Given this list of marker genes Drd4, Krt1, Gabarapl1, Krtap19-2, Krtap9-3, Dnah1, Tbca, Dync1li2, Pum1, Dnajb6 (NCBI Gene Id 23950), Saxo2, Arhgap33os, Fign, Cct2, Dcp1a, Krtap16-1, Smg5, Lmod2, Grsf1, Larp1, Krt14, Pbxip1, Grin2b, Mtcl2, Fbln5, Dnah12, Col1a1, Dcdc2c, Myom3, Snph, Chmp1b2, Synj1 (synaptojanin 1), Chmp4b, Dync1li1, Tstd1, Mical1, Slmap, Atxn2, Edc4, Hax1, Diaph1, Myo18b (NCBI Gene Id 74376), Katnb1, Coro1b, Cfap95, Misp, Larp4b, Diaph2, Luzp1, Spout1, Rptor, Cul3, Cfap210, Cfap144, Nudc, Spc25, Keg1, Igbp1, Vps11, Map2k1, Spast, Krt35, Eif4ebp2, Krt19, Fmn1, Krt7, Mex3b, Pierce2, Dnah17, Mefv (Mediterranean fever), Cfap77, Lman1, Fastk, Shroom3, Ska1, Septin9, Rpusd3, Amelx, Samd4b, Krtap6-5, Dync2li1, Cep57, Col5a3, Vmac, Dcdc2b, Ppp1r12b, Krtap5-5, Ythdc2, Endov, Arhgef25, Ryr1, Tiam1, Baiap2, Septin7, Rpgrip1l, Ogfod1, Ss18l1, Obscn, Lzts2, Ankrd34c, Map1b, Krtap19-3, Nme2, Gm5478, Kat8, Cenpq, Krtap5-2, Clmp, Inpp5d, Smarcb1, Ddx3y, Krtap3-3, Kif19a, Grip1, Spaca9, Pdlim7, Hook3 (NCBI Gene Id 76095), Efhc1, G3bp1 (NCBI Gene Id 97760), Golga2, Tubgcp6, Myh13, Pygm, Plk2, Trim54, Shank2, Limd1, Jph2, Smarcc1, Nrap, Aspm, Mapre1, Mid1ip1, Cep170, Dbnl, Col4a2, Kcnab2, Plk1, Calm3, Abra, Cenpu, Csrp1, Acta2, Lmna, Akap4, Saxo4, Cdk2ap2, Cnot8, Haus6, Odf4, Map1lc3b, Tuba4a, Tubgcp4, Gng12, Synpo2, Kif9, Usp3, Sco1, Pgm1 (phosphoglucomutase 1), Krtap19-9b, Clasp2, Krtap4-6, Des, Kif21a, Tubb1, Rps4x, Ttll3, Cenpf, Fam161a, Camsap2, Slc8a2, Tpm3-rs7, Eml2, Ccsap, Hnrnpa3, Matcap1, Keap1, Camsap3, Tmem214, Eid1, Calm2, Myo1f, Krt20 (NCBI Gene Id 66809), Cryab, Cct7, Frg1, Myl9, Tbcb, Chmp1a, Serpinb1a, Abcc9, Phf2 (PHD finger protein 2), Cdk5rap2, Myod1 (NCBI Gene Id 17927), Slc2a1, Ddx3x, Knl1, Krtap6-2, Kpna2, Lsm4, Rpl15, Bard1, Fhl3, Uhmk1, Krtap8-1, Adamtsl5, Marcks, Ankrd1, Krtap14, Tekt4, Cfdp1, Lmntd2, Asz1, Psen2, Cldn11, Cdt1, Opa1, Ctsg, Tnni2, Map10, Ribc2, Krt85, Klc3, Nsun2, Casc3, Fastkd1, Ino80, Krt84, Kif14, Myo9b, Tubgcp3, Poldip3, Kif16b, Radil, Tdrkh, Rab11a, Dpysl2, Piwil1, Nes, Lrpprc, Ccnb1, Cenph, Pcbp1, Kntc1, Cdk1 (NCBI Gene Id 12534), Cfap53, Lrrc39, Col11a1, Knstrn, Klc1, Arpc3, Ago1, Smtnl1, Haus1, Ctps2, Twf1, Togaram2, Cnot2, Krt222, Kcnn3, Cfap45, Tpgs2, Tubb5, Clip1, Bex6, Nefh (neurofilament, heavy polypeptide), Tcp11l1, Elavl1, Krt76, Casq2, Thsd4, Pls3, Tubg2, Timp4, Lin28a, Hsph1, Mfap5, Abi2, Cfap68, Apc, Eln, Gtsf1, Polb, Cfap161, Haus4, Dusp22, Saa2, Tnrc6c, Rassf3, Krt87, Shfl, Map6, Trp53bp1, Noct, Daxx, Cst3, Rps6, Pdlim2, Cyld, Tubb3, Cct3, Cenpe, Krt73, Fbn2, Lsm2, Tuba1c, Kif1a, Odf1, Mybpc3, Ezr, Lcp1, Firrm, Mta1, Mov10, Tnni3, Cald1, Krt40, Ttl, Nuf2, Slc1a4, Map6d1, Cfap96, Bag3, Mfap4, Katna1, Mt3, Ldb3, Fgf13, Pdlim3, Mael, Igfn1, Pbrm1, Eml6, Src, Gsk3b, Spmip10, Kif2b, Anapc16, Dctn4, Stmn1, Mfap2, Tuba1b, Cd2ap, Pyroxd1, Hnrnpu, Rac2, Kif17, Tmod4, Fhod3, Phf10, Ift70a1, Krt26, Synpo, Bin1, Nup160, Fbxo22, Mypn, Kif2c, Tmsb15b2, Rhoq, Stim1, Ndrg1, Eml1, Mapre3, Map1a, Cdk9, Lima1, Stau2, Whamm, Ift70b, Hnrnpa2b1, Ryr2, Tcp1, Arid2, Invs, Pinx1, Tmsb15l, Efcab6, Yes1 (NCBI Gene Id 22612), Krt5, Ttll9, Reep2, Klhl40, Mapt, Cobl, Zfp804a, Myh10, Npnt, Krt86, Hid1 (HID1 domain containing), Myot, Lsm3, Lsm1, Fkbp1a, Pde4dip, Fastkd5, Dync2h1, Gtf2b, Casp1 (NCBI Gene Id 12362), Krt74, Kif18a, Pnrc1, Kif28 (kinesin family member 28, NCBI Gene Id 383592), Krt83, Dynlrb2, Nrp1, Arhgap18, Klhl21, Nckap5, Phf6, Krt33a, Kif3b, Ghr, Cltc, Ldlrap1, Nckap5l, Tube1, Cfap141, Myh2, Adamts10, Gas2l2, Lmod1, Alppl2, Specc1, Qki, Isg20, Arhgef2, Rps6-ps4, Garre1, Myh11, Krt15, Trip10, Gramd2b, Kifc5b, Cfap107 (NCBI Gene Id 69364), Ccdc66, Fez1, Dcn, Ercc6l, Nup107, Tnk2, Fhdc1 (FH2 domain containing 1), Kcnj8, Shroom4, Synm, Rpusd4, Cenpm, Cct4, Flacc1, Grk3, Prpf4b, Dnai2, Tubg1, Fermt2, Ssb, Tmod3, Hnrnpl, Myh3, Tsc1, Bub1, Kif4, Tuba1a, Col27a1, Cimip2b, Zwint, Nefl, Krtap7-1, Sncaip, Nicn1, Tpr, Scn1a, Fmr1 (NCBI Gene Id 207836), Incenp, Nefm, Mis12 (NCBI Gene Id 67139), Xirp2, Nos1ap, Ybx1, Krtap3-2, Chmp7, Cfap90, Tcap, Snrpg, Krtap15-1, Mcrip2, Dmtn, Krt10, Tlk2, Dag1, Col4a1, Cdk5, Mfsd2a, Fxr1 (FMR1 autosomal homolog 1), Rpl28, Ror2, Cenpt, Zfand1, Bfsp2, Eif4a1, Mid1, Sdc4, Fam184a, Bloc1s6 (biogenesis of lysosomal organelles complex-1, subunit 6, pallidin), Tnnt1, Actg1, Reep4, Larp4, Vcp (valosin containing protein), Krt2, Gas7, Dcdc2a, Nup133, Col4a3, Smarca4, Aicda, Espn, Arl6, Col3a1, Rnf135 (NCBI Gene Id 71956), Spag8, Dctn5, Tjp1, Krt9, Map3k1, Pabpc4l, Myl4, Slc8a1, Amot, Psen1, Spmip9, Myom1, Cfap206, Syne1, Slain1, Abraxas2, Myh6, Sqstm1, Parvb, Upp2, Btbd1, Clip2, Prkaa2, Plk3, Myh4 (myosin, heavy polypeptide 4, skeletal muscle), Trim21, Bcl10, Synj2, Krt80, Hjurp, Dnah5, Rock1, Krt31, Myo18a, Kcne1, Ttll11, Gabpb1, Gck, Fxr2 (NCBI Gene Id 23879), Krtap19-4, Cspp1, Rock2, Ttll1, Htr2a, Mtus2 (NCBI Gene Id 77521), Trim5, Dnajb4, Nav1, Col11a2 (NCBI Gene Id 12815), Lrwd1, Exd1, Sptbn1, Mark2, Edc3, Shroom2, Fkbp4, Rangap1, Eif4enif1 (NCBI Gene Id 77952), Dis3l2, Dnai1, Poli, Snca, Hook2, Actn1, Tuft1, Pabpc2 (NCBI Gene Id 18459), Krtap26-1, Syne2, Map2k2 (NCBI Gene Id 26396), Whrn, Simc1, Tdrd7, Dhx36 (DEAH-box helicase 36), Tut4, Col1a2, Hrc, Tex14, Kifc2, Dynlt1b, Ctnnb1, Myl2, Tdrd1, Gsn, Krt34, Enkd1, Tpm2, Fsd1, Numa1, Dync1i1 (NCBI Gene Id 209813), Hoxd10, Patl1, Csrp2, Chmp2a, Was, Tnnt3, Pkp1, Scn8a, Krt75, Slc39a2, Jph1, Samd4, Kif5a (NCBI Gene Id 52905), Stau1, Rmdn3, Rab3d, Dnai7, Kmt5b, Cct5, Rtl1, Col6a1, Eif4e2, Ddx28, Cav3, Nin, Klhl22, Rplp0, Ythdf3, Fbxo32, Tnnc2, Dnm1, Tmem232, Kif3c, Tia1, Scn3b, H3f3a, Nbr1, Map3k11, Fyn, Cdc42, Trim71, Slc8a3, Ninl, Myoz2, Pde4d, Spry2, Csde1, Sybu, Ccnb1-ps, Champ1, Actg2, Wdr47, Tppp3, Pls1, Cct8, Jakmip1, Lmnb1 (lamin B1), Myl7, Glrx3, Cab39, Mybphl, Rc3h1, Efhc2, Ttk, Khsrp, Fkrp, Pdlim1, Tpt1, Krtap3-1, Fbf1, Psma4, Vps18, Dcp1b, Ndc80, Ago4, Zfp276, Krt27, Ido1, G3bp2, Csnk1d, Krt6b, Rusc1, Krt25, Tubb2b, Slc25a54, Kif13a, Actn4, Cimip2c, Adora2a, Ankrd2, Gas2l3, Synpo2l (synaptopodin 2-like), Acte1, Ppp3ca, Xrn1, Rnf4, Zc3h12d, Serp1, Col4a4, Kif5c, Dhx9, Myo3a, Pecam1, Eml4, Krtap21-1, Gdpd2, Igf2bp1, Myh8, Dnah2, Krt17, Adra1a, Spag17, Nanos2, Tuba8, Spc24, D1Pas1, Ttll7, Sgo1, Krtap29-1, Hcls1, Trim30c, Smarce1, Ttn, Nxf1, Sntb2, Krt79, Kif21b, Cyp2a4, Ang, Henmt1, Tnni1, Casp14, Krt36, Afap1, Dnaja3, Cma1, Sugt1, Trim32, Ift70a2, Cimap1d, Ackr2, Lmnb2, Myo5a, Fbxo28, Kif20b, Pabpc4, Appbp2, Myl1, Ddx1 (NCBI Gene Id 104721), Sec13, Plec, Fam83h, Cstpp1, Cenpi (NCBI Gene Id 245603), Togaram1, Plk5, Cnot9, Spmip11, Krt77, Tekt3, Dlg1, Nsl1, Kcna5, Kpnb1, Snrpb2, Macf1, Krt32, Nfkbiz, Ankrd23, Scn5a, Eif4e, Dvl1, Mybph, Myh7b, Dst, Hspa8, Sphkap, Nek2, Efemp2, Dcxr, Neb, Krt13, Xpo1, Actbl2, Dctn1, Sarm1, Nup85, Fbxl22, Cenpj, Sync, Rpl17, Fbp2, Rbpms, Rassf2, Piwil4, Slc4a1, Csrp3, Krt12, Bpi, Nme1, Krtap5-3, Sptan1, Adprhl1, Nde1, Tpx2, Capn3, Sco2, Socs1, Kif6, Odf2, Krt81, Zar1, Ttll10, Col4a6, Mdm1, Dnal4, Svil, Lmntd1, Cyp2a5, Parp4, Cfl2, Trappc12, Col4a5, Reep1, Myh14, Rac1, Odam, Helz, Rec8, Kctd6 (potassium channel tetramerisation domain containing 6), Khnyn, Ppp1r12a, Tubd1, Kcnn1, Zfp207, Clock, Sin3a, Dek, Rmdn2, Acta1, Nav3, Krtap19-5, Rbm4, Mybpc1, Cenpc1, Pof1b, Sgo2a, Kbtbd13, Pnrc2, Rbm20, Iqgap2, Rsph1, Ythdf1, Pdlim4, Cttn, Ltbp1, Ttll5, Aldoa, Dmd, Apc2, Hspb1, Fastkd3, Prkd1, Specc1l, Ahctf1, Twf2, Ddx25, Zc3h12c (NCBI Gene Id 330940), Ncl, Krt33b, Kif13b, Trim30d, Ska3 (spindle and kinetochore associated complex subunit 3), Myo9a, Dnm1l (NCBI Gene Id 74006), Psmc3, Lmod3, Jup, Mbnl1, Pgm5, Arf1, Kif7, Katnal2, Mmp2, Tppp, Cenpx, Coro1a, Chmp4c, Dync1h1, Hook1, Gjb6, Hnrnpk, Dynlt2a1, Btbd2, Actr3, Nup37, S100a1, Vim, Cfap126 (cilia and flagella associated protein 126), Upf2, Kif5b, Gigyf2, Krt42, Igf2bp3, Shtn1, Krtap19-1 (NCBI Gene Id 170657), Gabarap, Tekt2, Dnah8, Tpgs1, Fam110a, Col2a1, Aurkc, Tubgcp5, Sri, Atat1, Wipf1, Klc2, Krt6a, Ckap2, Ryr3, Kifap3, Tardbp, Rpl6l, Rpl4, Pmf1, Ythdf2, Dynlt3, Krt71, Map2, Dctn3, Parva, 3425401B19Rik, Trim12a, Shb, Myh15, Dcp2, Cct6a, Cnot7, Gm5414, Krtap5-4, Haus8, Kif1b, Krt4, Upf1, Ank1, Ddx4, Ttll8, Mtm1, Actb, Nexn, Eppk1, Zar1l, Calm1, Smg1, Nanos3, Rgs14, Mid2, Srprb, Palld, Bcas3, Kptn, Cenpp, Ribc1, Cavin4, Nudcd2, Bicd1, Trim30b, Pabpc1, Kif15, Smc1a, Ttll13, Vcl, Ttll4, Zw10, Celf1, Flnc, Psrc1, Atp2a1 (NCBI Gene Id 11937), Eif2s1, Rac3, Igf2bp2, Tdrd9, Itgb1bp2, Eif6, Myo1a, Clasp1, Clip3, Fkbp1b, Sumo1, Pabpc1l, Cep57l1, Chmp6, Ocm, Nbdy, Fmn2, Efhb, Krtap16-3, Actn2, Rpl6, Tbrg4, Smarcc2, Pqbp1, Dpp9, Mfap1a, Cdc20, Cacna1s, Krt24, Myl12a, Rmdn1, Mybpc2, Grb7, Wdr44, Itgb3bp, Dlc1, Tubal3, Sh2b2, Krt8, Pak1, Ina (internexin neuronal intermediate filament protein, alpha), Tektl1, Htt, Map1s, Haus3, Carhsp1, Flna, Jam3, Map1lc3a, Krtap5-1, Ubap2l, Katnal1, Casq1, Pawr, Dusp21, Csnk1a1, Kif19b, Kcnn2, Hipk2, Krt28, Pabpc6, Cpeb1, Tubb4b, Tpm3, Cep170b, Mex3a (mex3 RNA binding family member A), Dnm2, Ddx19a, Mfap1b, Aif1, Eif4g1, Ppp6r2, Mad2l1, Cmya5, Wdr90 (WD repeat domain 90), Ky (kyphoscoliosis peptidase), Kif12, Polr2g, Fhl2, Tubb6, Dynll2, Arfgef2, Chmp1b, Cfap52, Sirt2, Tuba3a, Nup43, Smpx, Homer1, Fbln1, Capzb, Ank3, Dcx, Krt78, Arc, Sympk, Nckap1, Kansl1, Ctsh, Kif27, Gpatch11, Lsm14b, Kif26b, Caprin1, Fam110c, Cirbp, Crhbp, Tnnc1, Eml5, Shroom1, Dbn1, Mx2, Dysf, Spef1, Dynll1, Rassf5, Txndc2, Sctr, Akna, Dsn1, Krt23, Cacna1d, Pcp4, Septin2, Kif26a, Wtip, Helz2, Ckap5, Kif20a, Cep295, Rtn2, Dapk3, Carmil1, Pum2, Atp2b4, Lrrc49, Tnrc6a, Krtap12-1 (keratin associated protein 12-1), Mov10l1, Haus5, Trim30a, Dpysl3, Eml3 (echinoderm microtubule associated protein like 3), Dcps (NCBI Gene Id 69305), Kif18b, Piwil2, Fbn1, Trim25, Gsk3a, Brd7 (bromodomain containing 7), Selenos, Arl3, Meikin, Map7d2, Hck, Dnal1, Saxo1, Kat2b, Fam161b, Cfap276, Spag6l, Bub3, Stk11, Tnrc6b, Ptges3, Col5a1, Smarcd2, Ablim2, Sgo2b, Iffo1 (intermediate filament family orphan 1), Mtmr12, Trpv4 (NCBI Gene Id 80591), Apoe, Psmc2, Nusap1, Prrc2c, Evpl, Kif23, Ggps1, Tubb2a, Gfap, Hsf1, Ago3, Kif2a, Avil, Haus7, Pafah1b1, Zc3h12a, Cbx5, Dnah3, Col10a1, Bex4, Kif1c, Rassf1, Capn6, Crebbp, Tdrd6, Ank2, Ssna1, Clip4, Kifc3, Dbi, Tppp2, Serpinb1c, Aurkb, Rcc2, Trim12c, Tpm4, Lsm6, Mapre2, Ccdc181, Smn1, Bfsp1, Saa1, Myl12b, Fbxw11, Spag4, Tfpt, Prickle4 (NCBI Gene Id 381104), Bysl, Ppp3cb (protein phosphatase 3, catalytic subunit, beta isoform), Trpc1, Cimap1a, Myh9, Cnot1, Myom2, Mad1l1, Ilk, Ltbp4, Fhl5, Ptpn20, Pan2, Hdac6, Flnb, Meaf6, Kif3a (NCBI Gene Id 192824), Septin6, Krt82, Myl3, Tnnt2, Anxa5, Dyrk3, Diaph3, Krt18, Ddx6, Gtse1, Nebl, Pycard, Map7, Smarcd1, Spmip5, Top1, Iffo2, Zfp36l1, Cfap20, Vps16, Gas2l1, Kif24, Dync1i2, Pierce1 (NCBI Gene Id 69327), Actl6b, Chmp5, Map9, Krt16, Col28a1, Mef2c, C9orf72, Mns1, Polr2m, Ago2, Tekt1, Stub1, Pacrg, Iqgap1, Dnm3, Krt72, Bbln, Krt39, Apobec3, Nufip2, Dynlrb1, Pcnt, Actc1, Emd, Arhgap4, Habp4, Myoz1, Haus2, Ncapd3, Myo1c (NCBI Gene Id 97728), Psma6, Taf5l (TATA-box binding protein associated factor 5 like), Myh7, Spmip8, Disc1, Dctn2, Gja1, Hdac4, Dsp, Gper1, Cenpo, Cnot3, Mtcl1 (microtubule crosslinking factor 1), Bmal1, Styxl2, Tdrd5, Zc3h12b, Rem1, Tubb4a, Pabpc5, Chmp3, Birc5, Trim63, Slain2, Ttll6, Bub1b, Myo6, Dazap2, Eif3b, Myzap, Sarnp, Ccdc57, Kif22, Cep162, Bod1, Lrrc10, Spag5, Cdk5r1, Ppl, Mcrip1, Fastkd2, Arpc2, Tubgcp2, Bcl2l11, Tchp, Rbfox1, Cacna1c, Cenpw, Lsm14a, Lum, Znfx1 (NCBI Gene Id 98999), Sorbs2, Reep3, Aif1l, Zwilch, Actn3, Cnp, Spdl1, Narf, Cenpk, Cenpn, Zfp36, Mical2, Kif11, Kat5, Nos1, Cenpl, Nup98, Cenpv, Rbpms2, Ppp2r5a, Tial1, Prph, Hnrnpab, Myh1, Mir23a, Actl6a, Myo1b, Bag2 (BCL2-associated athanogene 2), Rc3h2, Gas8, Klc4, Cenps, Ak1, Bmp10, Cimip2a, Aurka (aurora kinase A), Serpinb1b, Col5a2, Tek, Tpm1, Pdlim5, Ajuba, Ddx19b (DEAD box helicase 19b), Trub2, Dyrk1a, Dhx30, Cdk5rap3, Atxn2l, Klhl41, Tmod2, Asb2, Spmip6, Tekt5, Seh1l, Ctps1, Mtbp, Ndel1, Tmod1, Kifc1, Unc45b, Pan3, Cotl1, Krt90, Ska2, Chmp2b, Map4, Akap13, Nynrin, Prc1, Nme7, Orc2, Psma2, Anxa1, Patl2, Eif3a, Camsap1, Myoz3, Tektip1, Dctn6 (dynactin 6), Enkur, Ppp1cc, Pkp2, Rpl7, here is a description of the gene set: A cellular component that consists of an indeterminate number of proteins or macromolecular complexes, organized into a regular, higher-order structure such as a polymer, sheet, network or a fiber. Mouse Gene Set: GOCC_SUPRAMOLECULAR_COMPLEX studied in species Mus musculus